The following is a description of a gene set: Human Gene Set: GOMF_DNA_APURINIC_OR_APYRIMIDINIC_SITE_ENDONUCLEASE_ACTIVITY species: Homo sapiens Catalysis of the cleavage of the C-O-P bond in the AP site created when DNA glycosylase removes a damaged base, involved in the DNA base excision repair pathway (BER)., and this is the list of marker genes: HMGA1 (NCBI Gene Id 3159), NTHL1, APLF, NEIL1, APEX1, HMGA2, NEIL3, APEX2, POLB, NEIL2, ALKBH1, OGG1, RPS3 (NCBI Gene Id 6188), HMCES